Given this list of marker genes Bbx, Nsf, Kndc1, Hpse, Pkdcc, Unkl (unkempt family like zinc finger), Rab14 (NCBI Gene Id 99047), Dmxl2, Smarca2, Map3k2, Inpp5d, Tpm3, Cacna1b, Tmem65, Arpc1a, Glrb, Ank2, Smad1, Tafa1, Prdm1, Slc10a4, Ptma, Arl2bp, Rc3h2, Hbp1, Actr3 (NCBI Gene Id 74117), Csnk1g3, Pml, Cyfip2, Stx12, Minar2, Pced1b, Grk6 (NCBI Gene Id 26385), Itpripl2, Eif5a2, Gpatch11, Tbck, Atrx, Dph5, Scoc, Zfp653, Synpr, Adamts5, Gnat1, Abcc1, Anxa10, Spred1, Ttpal, Slx4ip, Rab27b, Esyt2, Creb3l1, Kras, Epsti1, En2, Adamts9, Col25a1, Trim33, Lrguk, Rmdn1, Nus1, Sp1, Slc8a1, Prkd1, Ap2m1, Nr6a1, Rdh10, Rabgap1l, Pkd2, Zhx1, Hipk3, Yipf4, Dynlt3, Wnk4, Rbm4b, Dkk1, Faf2, Hs3st5, Kcnc1, Ppp6r3, Idh1, Cenph, Smad5 (NCBI Gene Id 76327), Rnpc3, Rgs5, Ldhb, Ddhd2, Ubxn7, Cdk8, Dync1li2, 1110004F10Rik, Gls, Tcf12, Sgsm1, Mecp2, Gckr, Poglut1, Hivep1, here is a description of the gene set: from publication Chen Y, Wang X (PMID 31504780) studied in species Mus musculus Genes predicted to be targets of miRBase v22 microRNA mmu_miR_3073b_5p in miRDB v6.0 with MirTarget v4 prediction scores > 80 (high confidence targets). Mouse Gene Set: MIR_3073B_5P